Given this list of marker genes IDI1, FBXW4P1, EIF3E, PKD1, PTX3, LARP4B, INPP5A (NCBI Gene Id 3632), COX17, SNRPB2, FEZ1, TRAF6, here is a description of the gene set: Genes down-regulated in HT1080 (fibrosarcoma) cells by treatment with interferon gamma for 6 h. The pleiotropic activities of interferons (IFNs) are mediated primarily through the transcriptional regulation of many downstream effector genes. The mRNA profiles from IFN-alpha, -beta, or -gamma treatments of the human fibrosarcoma cell line, HT1080, were determined by using oligonucleotide arrays with probe sets corresponding to more than 6,800 human genes. Among these were transcripts for known IFN-stimulated genes (ISGs), the expression of which were consistent with previous studies in which the particular ISG was characterized as responsive to either Type I (alpha, beta) or Type II (gamma) IFNs, or both. Importantly, many novel IFN-stimulated genes were identified that were diverse in their known biological functions. For instance, several novel ISGs were identified that are implicated in apoptosis (including RAP46/Bag-1, phospholipid scramblase, and hypoxia inducible factor-1alpha). Furthermore, several IFN-repressed genes also were identified. These results demonstrate the usefulness of oligonucleotide arrays in monitoring mammalian gene expression on a broad and unprecedented scale. In particular, these findings provide insights into the basic mechanisms of IFN actions and ultimately may contribute to better therapeutic uses for IFNs. from publication Der SD, Zhou A, Williams BR, Silverman RH (PMID 9861020) studied in species Homo sapiens Human Gene Set: DER_IFN_GAMMA_RESPONSE_DN